Given this list of marker genes ERBB3, CREB1, FGF3, FGF8, JPH2, here is a description of the gene set: Human Gene Set: GOBP_REGULATION_OF_CARDIAC_MUSCLE_TISSUE_DEVELOPMENT species: Homo sapiens Any process that modulates the frequency, rate or extent of cardiac muscle tissue development.